The following is a description of a gene set: from publication Cao J, O'Day DR, Pliner HA, Kingsley PD, Deng M, Daza RM, Zager MA, Aldinger KA, Blecher-Gonen R, Zhang F, Spielmann M, Palis J, Doherty D, Steemers FJ, Glass IA, Trapnell C, Shendure J (PMID 33184181) The gene expression program underlying the specification of human cell types is of fundamental interest. The study authors generated human cell atlases of gene expression and chromatin accessibility in fetal tissues. For gene expression, the study authors applied three-level combinatorial indexing to >110 samples representing 15 organs, ultimately profiling ~4 million single cells. The study authors leveraged the literature and other atlases to identify and annotate hundreds of cell types and subtypes, both within and across tissues. Our analyses focused on organ-specific specializations of broadly distributed cell types (such as blood, endothelial, and epithelial), sites of fetal erythropoiesis (which notably included the adrenal gland), and integration with mouse developmental atlases (such as conserved specification of blood cells). These data represent a rich resource for the exploration of in vivo human gene expression in diverse tissues and cell types. Marker genes curated from the annotated cluster as represented in the Descartes Human Gene Expression During Development database. species: Homo sapiens Human Gene Set: DESCARTES_FETAL_HEART_LYMPHOID_CELLS, and this is the list of marker genes: NCR3, FCRL1 (Fc receptor like 1), MATK, CDKN2A, CD96, ENSG00000224610, LEF1-AS1, LINC02397, ZAP70, GZMH, LCK, LINC00861, TCF7, VPREB1, HRG-AS1, ENSG00000227863, IL2RB, FCMR, ICOS, IFNG-AS1 (NCBI Gene Id 100885789), SH2D1A, SELL, JCHAIN, MEAK7, CARD11 (caspase recruitment domain family member 11), TNFSF11, SEPTIN1, FCRL2, LINC01934, FCRL3, FLT3LG, FOXP3, FCRLA, KLRC1, IGLL1, PRF1 (perforin 1), LINC02481, NKG7, TCL1A, VPREB3, RASGRP1, LINC02325, TRAT1, BLK, TIGIT, GZMB, RAB25, IKZF3, CR2, POU2AF1, SHISAL2A, ISG20, CXCR3, CCR7, SIT1, SAMD3, KLRB1, GVINP1, PTPRCAP (NCBI Gene Id 5790), IGKC, SH2D1B, CD8B, TMIGD2, GPA33, ANTXRLP1, CD3G, CD19, CXCR6, TNFRSF13B, CD79B, THEMIS, CD52, CD7, LTA, CD27, TRBC2, CST7, SKAP1, GZMA, ACAP1, GNLY, XCL1, CD3D, SLAMF6 (NCBI Gene Id 114836), SCML4, GZMM (NCBI Gene Id 3004), KLRF1, LINC01215, MS4A1, LY9, LINC00426, CD5, SIRPG, GBP2, NCR1, UBASH3A, KLRC2, SLAMF1, CHI3L2, KLRK1, GZMK, PDCD1, LINC01222 (NCBI Gene Id 102800316), KLRC4-KLRK1, LINC01891, CD160, FCRL5, PAX5, TBX21, ITK, CRTAM, TNIP3, GPR171, IL18RAP